Given this list of marker genes Oaz2, Tomt, Sat2, Th, Npr1, Chka, Aoc1l2, Htr2c, Il4i1, Myo5a, Amd1 (NCBI Gene Id 432454), Kmo, Agtr2, Ddc, Satl1 (NCBI Gene Id 73809), Dao, Gdpd3, Tph2, Park7, Drd2, Rnls, Maoa, Naaa, Mecp2, Gch1, Prg3, Oaz3, Haao, Pebp1, Slc1a1, Itgam, Smox, Htr1a, Sncaip, Aoc1l1 (amine oxidase copper containing 1-like 1), Slitrk1, Afmid, Vcam1, Pnkd, Ly6e, Snca, Trh, Srm, Hand2, Mtpn, Abcc2 (ATP-binding cassette, sub-family member 2), Drd4, Nmnat2, Cyp2d22, Dmgdh, Gata3, Prkn, Rtl4, Insm1, Grin2a, Tacr3, Ido1, Aoc1l3, Sms, Hprt1, Epas1, Vhl, Chrnb2, Gde1, Gcdh, Akr1b1, Nadsyn1, Mdga1, Psg18, Rnf180, Tdo2, Sncb, Drd1 (dopamine receptor D1), Qprt, Vps35 (NCBI Gene Id 65114), Pde1b, Crhr2, Hdac6, Acmsd, Pnmt, Ido2, Slc6a3, Napepld, Comt, Gnat2 (G protein subunit alpha transducin 2), Sat1, Dbh, Moxd1, Npy, Fshr, Sult1d1, Aldh2, Odc1, Nr4a2, Tgfb2, Amd2, Atp7a, Aoc1, Gpr37, Moxd2, Dhps, Sult1a1, Azin2, Gdpd1, Ednra, Abhd4, Cyp1a1, Atp2b4, Hnmt (NCBI Gene Id 99068), Azin1, Kynu, Abat (4-aminobutyrate aminotransferase), Inmt, Hdac10, Paox, Oaz1, Ndufs4, Spr, Aoc2, Ldc1, Hdc, Agmat, Maob, Agtr1a, Kl, Aoc3 (NCBI Gene Id 11754), here is a description of the gene set: species: Mus musculus The chemical reactions and pathways involving any organic compound that is weakly basic in character and contains an amino or a substituted amino group. Amines are called primary, secondary, or tertiary according to whether one, two, or three carbon atoms are attached to the nitrogen atom. Mouse Gene Set: GOBP_AMINE_METABOLIC_PROCESS